The following is a description of a gene set: studied in species Homo sapiens Genes up-regulated in comparison of memory CD8 T cells versus those treated with IL4. Human Gene Set: GSE32423_CTRL_VS_IL4_MEMORY_CD8_TCELL_UP from publication Ventre E, Brinza L, Schicklin S, Mafille J, Coupet CA, Marçais A, Djebali S, Jubin V, Walzer T, Marvel J (PMID 22942430) Effects of IL-4 on CD8 T cells functions are largely unknown. IL-4 induces survival and proliferation of CD8 T cells, but several studies suggest that IL-4 could also affect several functions of CD8 T cells such as cytotoxicity. Our team has shown that IL-4 repress the expression of Ccl5 in vitro. To define more precisely the impact of IL-4 on CD8 T cells, we performed a whole genome expression microarray analysis of naive and memory CD8 T cells cultured in presence or absence of IL-4. This approach allowed us to define the IL4-gene-expression signature on CD8 T cells., and this is the list of marker genes: DYRK3, STK32B, DAPL1, GNB1L, LCN9, CFAP107, ZNF112 (zinc finger protein 112), FRAT2, ABHD17B, IL1RL1, PPP1R14B, SMG8, VNN1, ARSB, MTDH, CALCRL, ACTB, ARAP1, CRACDL, HYI, HS3ST3B1, RRM2, TRIM67, MREG, PITHD1, TWF1, ARRDC3, PTTG1, GARIN4, AHNAK (NCBI Gene Id 79026), IFT25, STK26, MAP4K4, PDGFA, ABTB3, HEMGN, NAA16, IQGAP2, EYA2, CERS6, SGMS1, RFX3, ARMCX1, SEC23A, RNF17, GALNT2, ESF1, MARCKS, WNK1, C19orf38, THEMIS2, CDK17, RHOB (NCBI Gene Id 388), ACKR3, LRBA, HVCN1, DGLUCY, CDK9, TMEM38A, ST6GAL2, ZXDB, TFEC, UBE2D2, FAM107B, STK10, ZDHHC2, ZFP36L2, TES, KCNH2, NME4, TMEM108, CXorf49B, C16orf89, PTGES2, ZBTB7A, RNF144A, RINT1, LPGAT1, SLC35D3, H2BC3, PUM1, BCL9L, GTF3C5, HSPA13, SYTL4, VWA8, SLC12A3, TMBIM1, SLC20A1, NR1D2, STK40, FAM222B, TMEM31, NCMAP, RUNDC1, CSNK2A2, CCNE2, PLXNB2, CMSS1, TGM3, GPC1, LYPD6B, NIPBL, RAD9B, FOXO3, RBSN, DSC1, DMRTA1, GIGYF1, EFNB3, SYT10, ARMCX2 (NCBI Gene Id 9823), KLHL12, TCEAL9, ABHD17C, TMEM216, ATP8B4, ASTE1, PLPP1, SYNE1, KCNV1, MED8, POLA1, KLRK1, CD320, SYPL1, MTMR10, CYP1A1, MYO7A, DLL1, RIF1, ZBED6, CCL5, MIER3, STK11IP, PYGL, TOB1, PRMT5, KLHL32, MSANTD2, HEY2, TMEM236 (NCBI Gene Id 653567), CMIP, VAMP3, HEATR5A, CD7, S100A4 (NCBI Gene Id 6275), FGF11, FAM241A, PADI2, ST3GAL6, EMB, CNGA4, NPAS4, CFAP418, UACA, CPM, CCDC120, PCSK2, ENC1, THBS2, CD3G, POU6F1, IL1F10, TRIM63, UNG, RHOBTB2, RAB11FIP4, PGM2L1, TAGLN2, APP, BBS9, CD81, DOCK10, NLRP4, KLF7, MYB, TMEM63A, NARS2, HAAO, BCOR, DNMBP, NFIC (NCBI Gene Id 4782), RCAN2, METTL2B, THOC2, HES2, LDLRAP1, RPS3A, MARCHF7, MEX3B, RGS11, PGAP1, OSBPL9, RSPRY1 (ring finger and SPRY domain containing 1), ADH1C, POU2F1, ITGAL, RNF2, CFAP68